The following is a description of a gene set: The chemical reactions and pathways resulting in the formation of purine nucleoside diphosphate, a compound consisting of a purine base linked to a ribose or deoxyribose sugar esterified with diphosphate on the sugar. species: Homo sapiens Human Gene Set: GOBP_PURINE_NUCLEOSIDE_DIPHOSPHATE_BIOSYNTHETIC_PROCESS, and this is the list of marker genes: AK2, AK1, AK5, GUK1, AK4, AK3 (adenylate kinase 3)